Given this list of marker genes HSPA1A, ENO1, POLR2K (RNA polymerase II, I and III subunit K), WARS1, SSR1, CXCL10, BCL7B, NAA30, PDP1, PSMA6, CD55, HLA-E, IRF1, PSMB2, NAMPT, ATP6V1C1, ITGA8, LATS2, PTGS2, TRIM21, TUBA4A, IL6, IDH3A, IMPA1, CSE1L, NFKBIA, IFNB1, SRSF7, RB1, TNFAIP3, SNRPA1, GGCX, PSMD2, IRF2, EIF4A1, HSPE1, PSMA2, ENO2, IDO1, SRF, ATF5 (NCBI Gene Id 22809), OAS2 (NCBI Gene Id 4939), LIG4, GCH1, MANF, PSMB8, IFI6, MLLT11, NFKB1, EMP2 (NCBI Gene Id 2013), NPM1, MSX1, SAR1A, RANBP1, CCL5, EGR1, GAL, ALAS1, RAB2B, STIP1 (stress induced phosphoprotein 1), SLC7A5, OAS1 (2'-5'-oligoadenylate synthetase 1), IFITM1, TFPI2, RIPK1, H2AC18, PFKP, GTF2B, SNRPB2, MX2, DNAJA1, PSMC1, NUBP1 (NCBI Gene Id 4682), GRPEL1, REC8, PML, IFI27, MX1, LGMN, SP100, PIM1, SLC39A14, PNP, GORASP2, FGFR1, TRIM22, EIF5, SCARB2, PSMD6, SYNGR2, NUP93, NR4A1, PSMA3, NR4A3, ISG15, KDM5C (NCBI Gene Id 8242), EIF1AX, IL7R, TAP1, MARK2, IL11 (NCBI Gene Id 3589), PLA2G4A, UBE2S, EIF4E, GBP1, BRCA2, TUBB2A, here is a description of the gene set: Mechanistic insights to viral replication and pathogenesis generally have come from the analysis of viral gene products, either by studying their biochemical activities and interactions individually or by creating mutant viruses and analyzing their phenotype. Now it is possible to identify and catalog the host cell genes whose mRNA levels change in response to a pathogen. We have used DNA array technology to monitor the level of approximately 6,600 human mRNAs in uninfected as compared with human cytomegalovirus-infected cells. The level of 258 mRNAs changed by a factor of 4 or more before the onset of viral DNA replication. Several of these mRNAs encode gene products that might play key roles in virus-induced pathogenesis, identifying them as intriguing targets for further study. studied in species Homo sapiens from publication Zhu H, Cong JP, Mamtora G, Gingeras T, Shenk T (PMID 9826724) Human Gene Set: ZHU_CMV_ALL_UP Up-regulated at any timepoint following infection of primary human foreskin fibroblasts with CMV